The following is a description of a gene set: PTK6 Regulates RTKs and Their Effectors AKT1 and DOK1 Human Gene Set: REACTOME_PTK6_REGULATES_RTKS_AND_THEIR_EFFECTORS_AKT1_AND_DOK1 species: Homo sapiens, and this is the list of marker genes: DOK1, PTK6, UBC, UBB, UBA52, CBL, AKT1, RPS27A, ARAP1